The following is a description of a gene set: species: Homo sapiens Enables the transfer of ADP, adenosine diphosphate, from one side of a membrane to the other. Human Gene Set: GOMF_ADP_TRANSMEMBRANE_TRANSPORTER_ACTIVITY, and this is the list of marker genes: SLC25A5, SLC25A41, SLC25A17, SLC25A31, SLC25A6, SLC25A24, SLC35B1, SLC25A4, SLC25A42, SLC17A9, SLC25A23